The following is a description of a gene set: A protein complex that does not contain either a TATA-binding protein (TBP) or a TBP-like factor, but is composed of several TAFIIs and other proteins, including a histone acetyltransferase. This complex is able to nucleate transcription initiation by RNA polymerase II, can mediate transcriptional activation, and has histone acetyltransferase activity. species: Mus musculus Mouse Gene Set: GOCC_TRANSCRIPTION_FACTOR_TFTC_COMPLEX, and this is the list of marker genes: Taf6, Atxn7l3, Taf5l, Usp22, Eny2 (ENY2 transcription and export complex 2 subunit), Taf2, Taf5, Kat2a, Tada3, Taf12, Trrap, Taf9, Taf4, Taf7, Atxn7, Taf9b, Taf10 (NCBI Gene Id 24075, TATA-box binding protein associated factor 10), Supt3